The following is a description of a gene set: Intrinsic Pathway of Fibrin Clot Formation Human Gene Set: REACTOME_INTRINSIC_PATHWAY_OF_FIBRIN_CLOT_FORMATION studied in species Homo sapiens, and this is the list of marker genes: GP9, GP1BA, F9, GP1BB, KNG1, PROC (NCBI Gene Id 5624), F8, F12, SERPINC1, A2M, PRCP, PROS1, F10, F2, SERPINA5, SERPINE2 (NCBI Gene Id 5270), SERPING1, GP5, C1QBP, SERPIND1, KLKB1, VWF, F11